Given this list of marker genes THBS1, CDH5, FBLN1, MFAP2, ITGB3 (integrin subunit beta 3), ITGA2B, CD47, here is a description of the gene set: Binding to fibrinogen, a highly soluble hexameric glycoprotein complex that is found in blood plasma and is converted to fibrin by thrombin in the coagulation cascade. Human Gene Set: GOMF_FIBRINOGEN_BINDING species: Homo sapiens